Given this list of marker genes Hspa5, Cops2, Plcg1, Epb41l2, Grap, Cops7b, Atp5f1a, Hspa1a, Dynll1 (dynein light chain LC8-type 1), Hspa1l, Nckipsd, Cops5, Cops6, Wdr6, Myh9, Grb2, Flot1, Amot, Gps1, Cops8, Tespa1, Amotl1, Tmod1, Basp1, Hsp90ab1, Cops7a, Cops9, Cops4, Lat, Dcaf1, Sla, Cops3, Themis, Dock7, here is a description of the gene set: studied in species Mus musculus Mouse Gene Set: GOCC_COP9_SIGNALOSOME A protein complex that catalyzes the deneddylation of proteins, including the cullin component of SCF ubiquitin E3 ligase; deneddylation increases the activity of cullin family ubiquitin ligases. The signalosome is involved in many regulatory process, including some which control development, in many species; also regulates photomorphogenesis in plants; in many species its subunits are highly similar to those of the proteasome.